The following is a description of a gene set: Genes predicted to be targets of miRBase v22 microRNA mmu_miR_6950_5p in miRDB v6.0 with MirTarget v4 prediction scores > 80 (high confidence targets). Mouse Gene Set: MIR_6950_5P species: Mus musculus from publication Chen Y, Wang X (PMID 31504780), and this is the list of marker genes: Spef1, Prn, Mgat3, Mtcl2, Fam227a, Slamf8, Mdga2, Cnot8, Nudt7, Map4k4, Gck, Wbp1l, Camk1d, Slc27a4, Sel1l, Asgr1, Psca, Aldob, Astl, Natd1, Edaradd, Dhrs3 (NCBI Gene Id 20148), Car10, Plscr3, Prr9, Sh3pxd2a, 9130008F23Rik, Cps1, Ncoa2, Fxyd1, Cyp27b1, Fxyd7, Sphk2, Ulk2, Bspry, Prlr, Samd1, Utp14b, Tmem239, Gas7, Baiap2l1, Nav1, Shisa7, Bcl9, Slc18a2, Sult1a1, Spout1, Chst11, Eif4b, Ankrd13b (NCBI Gene Id 268445), Trir, Aoc3, Gpd1, Creld2, Atg9a, Rpsa, Cldn15, Nkd1, Irx4, Rpl5, Limd2, Cobl, Adgre1, Raver1, Homer1, Ntpcr, Atxn7, D630045J12Rik, Gstm4, Rnft2, Zbtb4, Lin28a, Syne3, Rnf24, Hoxc8, 2700062C07Rik, Cdv3, Rtel1, Cd300lb, Wnt9b (NCBI Gene Id 22412), Septin12, Epg5, Prdm16, Camk1g, Spred1, Chd1, Cep85, Prkdc, Aak1, Nptxr, Ndufaf7, Ptprt (protein tyrosine phosphatase receptor type T), Tsc22d3 (TSC22 domain family, member 3), Zfp455, Nipsnap1, Axin2, Nab2, Slc30a9, Wnt4, Dlx3, Pde4b, Prpf31, Timm10, Zeb2, Chst15, Top2a, Tbc1d2b, Wnt7a, Ly6h, Tmem45a, Amotl1, Cldn4, Tmem141 (NCBI Gene Id 99059), Fscn3, Hbegf, Arhgap15, Ppp1r3e, Aldh18a1, Slc31a1, Zap70, Dnajc25, Bmf, Insr, Immt, Ildr1, Dars1, Bnip1, Thada, Pik3c2b (NCBI Gene Id 240752), Scube1, Npcd, Dnajb6, Chrm1, Tmem233, Dgki, Prkch, Dap, Usp49, Ring1, Syn3, Trp73, Prnd, Ttll6, Robo2, Abcg4, Naip5, Pramel32, Eda, Hhat, Gins3